Given this list of marker genes GSK3B, PPP2R5A, AMER1, CSNK1A1 (NCBI Gene Id 55416), PPP2CB, PPP2R1A, PPP2R5E, PPP2R5C, PPP2R5D, PPP2R5B, AXIN1, CTNNB1, APC, PPP2R1B, PPP2CA, here is a description of the gene set: species: Homo sapiens part of: Signaling by WNT in cancer GSK3beta is subject to in-frame missplicing in CML stem cells resulting in the production of mutant protein that lacks the AXIN and FRAT binding domains. Cells containing this mutant GSK3beta show elevated levels of nuclear beta-catenin and enhanced TCF-dependent reporter activity. Reactome Pathway: Signaling by GSK3beta mutants